Given this list of marker genes RPRD2, BRF1, RPRD1B, RPAP2, BRF2, TAF10, ERCC3, GTF2H3, RPRD1A, GTF2B, GTF2A1, POLR2M, RECQL5, here is a description of the gene set: Human Gene Set: GOCC_TRANSCRIPTION_PREINITIATION_COMPLEX A protein-DNA complex composed of proteins binding promoter DNA to form the transcriptional preinitiation complex (PIC), the formation of which is a prerequisite for transcription. studied in species Homo sapiens